Given this list of marker genes EDNRB, HERC1, PIGN, HNF4A, DIS3L2, SHOC2, FIBP, IFT74, SPIN4, GLI3, KCNJ11, RTL1, MEG3, CEL, DNM2, PDX1, SOS1, APPL1, ABCC8, ANK3, ABCC9, KMT2C, RIT1, PTCH1, NEUROD1, BIN1, HNF1A, TMCO1, GCK, RNF135, MTMR14, PTEN, NDST1, RYR1, ZFX, PIGL, MYF6, PIGT, DICER1, SUFU, INS, PAX4, BLK, AKT2 (AKT serine/threonine kinase 2), MTOR (NCBI Gene Id 2476), KLF11, DLK1, RAF1, BRAF, EHMT1, PIGA, UCP2, ODC1, here is a description of the gene set: Large for gestational age species: Homo sapiens Human Gene Set: HP_LARGE_FOR_GESTATIONAL_AGE The term large for gestational age applies to babies whose birth weight lies above the 90th percentile for that gestational age.